The following is a description of a gene set: At the level of transcription, expression of the RUNX1 transcription factor is regulated by two alternative promoters: a distal promoter, P1, and a proximal promoter, P2. P1 is more than 7 kb upstream of P2. In mice, the Runx1 gene is preferentially transcribed from the proximal P2 promoter during generation of hematopoietic cells from hemogenic endothelium. In fully committed hematopoietic progenitors, the Runx1 gene is preferentially transcribed from the distal P1 promoter. In human T cells, RUNX1 is preferentially transcribed from P1 throughout development, while developing natural killer cells transcribe RUNX1 predominantly from P2. Developing B cells transcribe low levels of RUNX1 from both promoters.<br>RUNX1 mRNAs transcribed from alternative promoters differ in their 5'UTRs and splicing isoforms of RUNX1 have also been described. The function of alternative splice isoforms and alternative 5'UTRs has not been fully elucidated.<br>During zebrafish hematopoiesis, RUNX1 expression increases in response to NOTCH signaling, but direct transcriptional regulation of RUNX1 by NOTCH has not been demonstrated. RUNX1 transcription also increases in response to WNT signaling. BothTCF7 and TCF4 bind the RUNX1 promoter, and RUNX1 transcription driven by the TCF binding element (TBE) in response to WNT3A treatment is inhibited by the dominant-negative mutant of TCF4. In developing mouse ovary, Runx1 expression is positively regulated by Wnt4 signaling.<br>Studies in mouse hematopoietic stem and progenitor cells imply that RUNX1 may be a direct transcriptional target of HOXB4.<br>Conserved cis-regulatory elements were recently identified in intron 5 of RUNX1. The RUNX1 breakpoints observed in acute myeloid leukemia (AML) with translocation (8;21), which result in expression of a fusion RUNX1-ETO protein, cluster in intron 5, in proximity to these not yet fully characterized cis regulatory elements.<br>At the level of translation, RUNX1 expression is regulated by various microRNAs which bind to the 3'UTR of RUNX1 mRNA and inhibit its translation through endonucleolytic and/or nonendonucleolytic mechanisms. MicroRNAs that target RUNX1 include miR-378, miR-302b, miR-18a, miR-675, miR-27a, miR-17, miR-20a, miR106 and miR-215.<br>At the posttranslational level, RUNX1 activity is regulated by postranslational modifications and binding to co-factors. SRC family kinases phosphorylate RUNX1 on multiple tyrosine residues in the negative regulatory domain, involved in autoinhibition of RUNX1. RUNX1 tyrosine phosphorylation correlates with reduced binding of RUNX1 to GATA1 and increased binding of RUNX1 to the SWI/SNF complex, leading to inhibition of RUNX1-mediated differentiation of T-cells and megakaryocytes. SHP2 (PTPN11) tyrosine phosphatase binds to RUNX1 and dephosphorylates it.<br>Formation of the complex with CBFB is necessary for the transcriptional activity of RUNX1. Binding of CCND3 and probably other two cyclin D family members, CCND1 and CCND2, to RUNX1 inhibits its association with CBFB, while binding to CDK6 interferes with binding of RUNX1 to DNA without affecting formation of the RUNX1:CBFB complex. Binding of RUNX1 to PML plays a role in subnuclear targeting of RUNX1.<br>RUNX1 activity and protein levels vary during the cell cycle. RUNX1 protein levels increase from G1 to S and from S to G2 phases, with no increase in RUNX1 mRNA levels. CDK1-mediated phosphorylation of RUNX1 at the G2/M transition is implicated in reduction of RUNX1 transactivation potency and may promote RUNX1 protein degradation by the anaphase promoting complex. part of: Transcriptional regulation by RUNX1 Reactome Pathway: Regulation of RUNX1 Expression and Activity species: Homo sapiens, and this is the list of marker genes: PTPN11, MIR20A, MIR302B, CDK6, CCND3 (NCBI Gene Id 896), PML, TNRC6B, RUNX1, CCND1, MIR17, MIR27A, MIR378, H19, AGO3, AGO1, MIR18A, AGO2, CCND2, TNRC6C, MOV10, CBFB, MIR675, TNRC6A (trinucleotide repeat containing adaptor 6A), AGO4, MIR106A, SRC, MIR215